Given this list of marker genes OR11A1, BCAN, XRCC3, SCX, PCYOX1, COL6A3, BMP8B, NECAP2, OR2A20P, RFX4, EEF1AKMT1, AMY1B (amylase alpha 1B), GCK, LINC01618, HBE1, STAR, CASTOR1, IFT70A, TMSB4X, CLUH, RTL8B, MROH8 (NCBI Gene Id 149674), EML2, IGFBP1, GDF1, MIR7-3HG, TMEM70, RNU4-2, PKP2, ING3, SPICE1 (NCBI Gene Id 152185), CAMK1G, RNU4-1, ZNF320, FRMPD2B, G6PC1, ARTN, TMEM191A, MPI, ZNF93, here is a description of the gene set: studied in species Homo sapiens Human Gene Set: ANDERSON_BLOOD_CN54GP140_ADJUVANTED_WITH_GLA_AF_AGE_18_45YO_3DY_UP from publication Anderson J, Olafsdottir TA, Kratochvil S, McKay PF, Östensson M, Persson J, Shattock RJ, Harandi AM (PMID 29535712) Systems biology approaches have recently provided new insights into the mechanisms of action of human vaccines and adjuvants. Here, we investigated early transcriptional signatures induced in whole blood of healthy subjects following vaccination with a recombinant HIV-1 envelope glycoprotein subunit CN54gp140 adjuvanted with the TLR4 agonist glucopyranosyl lipid adjuvant-aqueous formulation (GLA-AF) and correlated signatures to CN54gp140-specific serum antibody responses. Fourteen healthy volunteers aged 18-45 years were immunized intramuscularly three times at 1-month intervals and whole blood samples were collected at baseline, 6 h, and 1, 3, and 7 days post first immunization. Subtle changes in the transcriptomic profiles were observed following immunization, ranging from over 300 differentially expressed genes (DEGs) at day 1 to nearly 100 DEGs at day 7 following immunization. Functional pathway analysis revealed blood transcription modules (BTMs) related to general cell cycle activation, and innate immune cell activation at early time points, as well as BTMs related to T cells and B cell activation at the later time points post-immunization. Diverse CN54gp140-specific serum antibody responses of the subjects enabled their categorization into high or low responders, at early ( < 1 month) and late (up to 6 months) time points post vaccination. BTM analyses revealed repression of modules enriched in NK cells, and the mitochondrial electron chain, in individuals with high or sustained antigen-specific antibody responses. However, low responders showed an enhancement of BTMs associated with enrichment in myeloid cells and monocytes as well as integrin cell surface interactions. Flow cytometry analysis of peripheral blood mononuclear cells obtained from the subjects revealed an enhanced frequency of CD56<sup>dim</sup> NK cells in the majority of vaccines 14 days after vaccination as compared with the baseline. These results emphasize the utility of a systems biology approach to enhance our understanding on the mechanisms of action of TLR4 adjuvanted human vaccines. Genes up-regulated in blood 3d vs 0hr in adults (18-45) after exposure to CN54gp140 adjuvanted with GLA-AF, time point 3D, administered i.m.